Given this list of marker genes TMSB15B, MRPS16, UBOX5-AS1, C3orf18, SHARPIN, HDC, CCDC63, PARP2, ADPRM, FBXO45, IRGM, GTF2A2, ZNF302, PSPN, DRAP1, OSM, WDR75 (NCBI Gene Id 84128), CTDSPL2-DT, FAM209A, PAQR4, LMX1B-DT, LINC01629, ENSG00000225457, MRPL3, AGAP10P, RPLP0P9, LINC02482 (long intergenic non-protein coding RNA 2482), MICB, MINAR2, SF3B4, LINC00847, BRF2, KDM7A-DT, TIGD5, RNF26, TMEM26-AS1, CNEP1R1, LINC01681, LYRM7, STEAP1B-AS1, ING3, SCAT2, EEF1GP7, ENSG00000217455, ENTR1, PLEKHA3, RN7SL823P, ST3GAL1-DT, AFG3L2, ADO, NDUFC1, TPCN2 (two pore segment channel 2), TTC36-AS1, TMED7, CEP131, LINC02549, BCKDHA, SLC52A2, IL5RA, DDX11-AS1, EIF2AK4, LIG4, PANK4, ZNF615, LINC02256, TIMM50, PPM1M, ALDH1L1-AS2, VSIG10L, ESS2, MRPS31P5, POLRMT, MAN1A2P1, IRX4-AS1, PPP1R13B-DT (NCBI Gene Id 145216), ACBD6, INE1, PTGS2, HEATR5A-DT (HEATR5A divergent transcript), ZC3HC1, MIR497HG, BECN1, EIF1B, TMEM30A-DT, C1orf174, RBM15, TTC4, NXF1 (nuclear RNA export factor 1), TBX5-AS1, ZDHHC24, THYN1, ARFIP2, IMP3, CCDC86-AS1, FLNB-AS1, HMGB1P41, BIRC5, CRELD1, CYP2U1-AS1, MLIP-AS1, LAMTOR5-AS1 (LAMTOR5 and SLC16A4 antisense RNA 1), ACBD5, CAMTA2, HENMT1, RNU2-22P, COA6, LRRC52-AS1, RPL23P6, EPX, PGAM5, FBXO8, ZNF415, COX17P1, HSD17B13, SLC6A3, DBP, NLRP12, CENPW, TRAPPC2B, TRABD-AS1, LINC01948, MCUR1, ZNF687, LINC02324, MMACHC, DCUN1D5, ZFP41, NAALADL1, SLC5A5 (solute carrier family 5 member 5), ATP5F1EP2, UCK1, RPL35P5, POLR3K, RPS2P54, C9, RHOXF1-AS1, CAMSAP1-DT, CT55, USP39, ENSG00000267058, SPAAR, ZSCAN2, LINC01476, SNRNP25, ZNF22, POLR1E, SYS1-DBNDD2, STRN4, RN7SL308P, HK2-DT, TFAMP1, NDUFS2, LINC02925, R3HCC1, FBXL8, PITRM1-AS1, NSL1, SNRPA1, LINC01224, ANAPC13, DAND5, LINC02869, SMIM8, LARS2-AS1, PBK, MAP10, RPL39P5, PPP1CC, WDR55, MTFR1L, ZSCAN16, ZNF304, MYOCD-AS1, COQ3, GEMIN4, RPS3AP49, TRPM2-AS, ZNF517, PLD6, VBP1, MS4A3, MEP1B, TMEM250, NOP16, ZBTB34, PCGF1, LINC00680, TRO, ZNF18 (zinc finger protein 18), CCNB3, ATOX1-AS1, CDK15, TNMD, PDE6G, CLC, SDHAP2, MADCAM1-AS1, CLEC4OP, TOMM40L, HMGN2, ALG3, GTF2IRD1P1, ACTR1B, GPT, PTGDR2, RPS23P8, CCDC115, GAR1, ZNF132-DT, GCSH, GPATCH3, MRPL40, PIWIL2-DT, BCS1L, FLJ46284, PCDHB6, ZCCHC4, ENSG00000232581, SF3B6 (splicing factor 3b subunit 6), PDK2 (NCBI Gene Id 5164), TMC3-AS1, GNG10, NDUFB5, SDHAF3, CRIPT, LAMTOR5, ADAD1, COMMD8, CC2D1B (coiled-coil and C2 domain containing 1B), ZBTB20-AS1, ZNF32, TOPORS (NCBI Gene Id 641432), PEAK3 (PEAK family member 3), GALNT16-AS1, PRELID1, THAP7-AS1, DBIL5P, CTXN3, MKRN2, THAP9, LINC02701, LINC02552 (long intergenic non-protein coding RNA 2552), DHX16, GTF3A, PSMD6-AS1, ZNF605, FRAT2, NICN1, SAC3D1, SNHG10, TRIM21 (NCBI Gene Id 6737), RLIM, here is a description of the gene set: from publication Cao J, O'Day DR, Pliner HA, Kingsley PD, Deng M, Daza RM, Zager MA, Aldinger KA, Blecher-Gonen R, Zhang F, Spielmann M, Palis J, Doherty D, Steemers FJ, Glass IA, Trapnell C, Shendure J (PMID 33184181) Marker genes curated from the annotated cluster as represented in the Descartes Human Gene Expression During Development database. The gene expression program underlying the specification of human cell types is of fundamental interest. The study authors generated human cell atlases of gene expression and chromatin accessibility in fetal tissues. For gene expression, the study authors applied three-level combinatorial indexing to >110 samples representing 15 organs, ultimately profiling ~4 million single cells. The study authors leveraged the literature and other atlases to identify and annotate hundreds of cell types and subtypes, both within and across tissues. Our analyses focused on organ-specific specializations of broadly distributed cell types (such as blood, endothelial, and epithelial), sites of fetal erythropoiesis (which notably included the adrenal gland), and integration with mouse developmental atlases (such as conserved specification of blood cells). These data represent a rich resource for the exploration of in vivo human gene expression in diverse tissues and cell types. Human Gene Set: DESCARTES_MAIN_FETAL_CLC_IL5RA_POSITIVE_CELLS studied in species Homo sapiens